The following is a description of a gene set: Human Gene Set: MURARO_PANCREAS_ALPHA_CELL from publication Muraro MJ, Dharmadhikari G, Grün D, Groen N, Dielen T, Jansen E, van Gurp L, Engelse MA, Carlotti F, de Koning EJ, van Oudenaarden A (PMID 27693023) studied in species Homo sapiens, and this is the list of marker genes: OGT, MUC13, DZIP3 (DAZ interacting zinc finger protein 3), APOH (apolipoprotein H), AK2, C12orf75, SLC38A10, ENSG00000274253, P4HTM, GDI1, NENF, ABLIM1, PRKCE, CDC42EP3, TCEAL3, ARRDC4, CHGB (NCBI Gene Id 1114), PVR, ISL1, ZBED5-AS1, SMOC1, GPR137B, KCNMA1, TENT5C, SERTAD4BP, CD46, STMN1, ALDH1A1, PCDHB4, PTGER3, AP1S2, SH3RF1, CHKA, DACH1, ENAM, DNAJA4, COX17, NME4, CTNND2, PDZK1, SPCS1, PLPPR4, SEM1, PARM1, CALM1, BEX1, UBB, FAR2P2, SSTR1, PTP4A3, H1-10, NPDC1, CFC1, RGS4, KCNK16, IVNS1ABP, IRF6, SNED1, NDUFA1, SCG5, UNC13A, FAM167A, NAA20, RSAD2, MANEAL (mannosidase endo-alpha like), HIGD1A, TRAK1, PTPRN, GK5, SGSM1, ESYT1, INA, ST8SIA1, CADPS, HERC5, MAGED2, TBL1X, FAP, PDE4D, KCNA5, KCNJ6, MBOAT2, CMIP, SLC7A14, SYP, EGFEM1P, ITM2B, TXNDC11, SSBP2, THEM6, COPE, G6PC3, MTMR7, IDS, PAK3, SLC37A4, ANAPC11, CKB, PDK4, SLC30A8, NDUFAF8, FAM210B, CPNE3, FYB2, LDLRAP1 (NCBI Gene Id 81862), ARL3, GSTA4, LOXL4, KCNMB2 (potassium calcium-activated channel subfamily M regulatory beta subunit 2), DPP4, SMIM24, PKM, TCTN1, CALCOCO2, TMEM17, TMEM176A, MYEF2 (myelin expression factor 2), HS6ST3, GCG, SCN3B, ABHD16A, PAX6, PITRM1, HLA-A, PSEN2, GFOD2, RIN2, GGA2, ANKH, F10, RNASE4 (ribonuclease A family member 4), CKMT1A, FGF12, PTPRD, CAMK2B, AP3B2, NPNT, NLGN2, REC8, PIGT, MMRN1, TMEM59 (NCBI Gene Id 9528), KCNQ1OT1, LRP11, HECTD4 (NCBI Gene Id 283450), CNIH2, COX7A2, CSRNP3, PGAP1, NOMO1, NSG2, BUD23, GC, PRPS1 (NCBI Gene Id 8254), ENPP2, CUTA, MPC2, CNNM1, FXYD3, BEX3, MLLT11, GPX3 (glutathione peroxidase 3), PLIN3, TMEM260, SCAMP1, HSD17B14, MRC1, GNG2, TM4SF4, CNKSR3 (CNKSR family member 3), NAV1, PAM, NOVA1, PLCE1, RGS9, RAB27A, TTR, PPP3CB, LUC7L3, ATP5MG, GNAS, NUCB2, GUSBP14, SERPINE2, ANXA6 (annexin A6), LSAMP, PRAF2, COX8A, BIVM, REEP4, GNG4, NFASC, MBD4, FXYD6, DEPP1, RGS17, NEUROD1, MOB1B, NOL4, SLC8A2, SH3GL2, PLK2 (NCBI Gene Id 10769), DAPK2, VAMP2, QPCT, ITPR1, IL6R, HMGB3, OAZ1, TMEM60, SLC22A17, UBL5, NRXN1, SGPL1, MAFB, ADCY1, IFI27L2, TMED3, CACNA1A, CSGALNACT1, CD99L2, ELAPOR1, OCRL, CD36, ZNF618, SMDT1 (single-pass membrane protein with aspartate rich tail 1), SIK3, GRM4, ASPH, ZKSCAN1, PFN2, PRKAR1A, GPAA1, SPC25, POPDC3, NAXE, ADA2, PKD2, C21orf58, GLS, ACVR1C, PLPP5, CRTAC1, SPTSSB, GPC6, HNF1A-AS1, ARX, NDUFB8, CEACAM19, PTPRN2, EPB41L3, MAMLD1, PTGER4, BEX2, SGSM2, ST8SIA3, BTG2, HIPK2, AIG1, KIAA0319, ZNRF1, ANXA7, TMEM178B, SDC2, VKORC1, RCAN2, SEC14L1, IFI6, PDXDC2P, C2CD4B, CHST9, CKMT1B (NCBI Gene Id 1159), CNTN4 (NCBI Gene Id 53943), CITED2, TOX3, TMEM9, TMEM258, CPNE8, USP25, PPP1R3B, UQCRQ (ubiquinol-cytochrome c reductase complex III subunit VII), ST18, PCSK2, PTS, ACLY, PYROXD2, DNER, PCDH17, SLC9A7, TENT5A, TCEAL5, SEZ6L2, MAGI2-AS3, NEURL1, COA3, TTC8, ADCY2, SESN3, SDK1, TUBA1B, STX16 (NCBI Gene Id 8675), FAM110B (NCBI Gene Id 90362), SLC29A1, CLU, VDR, A1CF, NDUFA7, ENPP1, UPB1, CPLX2, SERPINI1, SYT4, ROMO1, RAP1GAP2, EPHX2, FNDC3A, OSBPL6, KIF12, LGI2, VCF2, QDPR, TMEM176B, RIMBP2, HMGN3, NDUFC1, SDF2L1, VWA5B2, ZBTB41, SPINT2, YIPF6, MYL6 (myosin light chain 6), BCAR3, EDIL3, TMEM147, GDA, RADX, KCNK17 (potassium two pore domain channel subfamily K member 17), JADE1, TMX4, STXBP6, LINC00261, MAB21L3, CST3, CD200, FADS1, NUCB1, TCEAL2 (transcription elongation factor A like 2), CAPZB, GNE, PPP1R1A, APOL4, STX11, FBXW7, CNTN1, H2BC21, RUNDC3A, CRELD1, DNPH1 (2'-deoxynucleoside 5'-phosphate N-hydrolase 1), RHBDD2, BEX5, RAB29, USH1C, KLHL41, SLC38A4, PLP2 (proteolipid protein 2), NBDY, TUNAR, CCDC86, PTPRT, RAB26, PRKAG2-AS1, VSTM2L (NCBI Gene Id 128434), TSPAN2, CD82, IDI1, CPE, SLC35G2, FBXL16, KCNJ3, PDE3B, AGT, TBC1D9 (TBC1 domain family member 9), RAB3C, RAB3GAP2, MYH10, TMEM205, RTN1, GRAMD4, WDR59, PAPSS2, GADD45G, PNMA2 (PNMA family member 2), MAP7D3, BCKDHB, CEP126, SMARCA1, CERK, TMEM14A, SNHG6, IRX2, NPTXR, RFX6, LDB2, SPOCK3, MALAT1, ATP5MF, NT5C3A, ATP6AP2, IFIH1, RAB3B, LRATD1, CAMK2G, BACE1, LRRTM2, CD164, GNAI1, NR4A2, COPZ1, GRK3, MIA2, SSTR2, CD63, SERF2, ATRAID, VPS41, RTL5, TMEM80, CRYBA2, ATP2B1, FAM47E, CHGA, RPS6KA3, ATP6AP1, DNAJC12, RASSF5, MAGI2, BOLA3, RAB11A, TBC1D30, VPS26B, PEMT, PROX1, GCNT1, YIPF2, KCTD12, EMB, HMGN2, KDELR1, QSOX2, C1orf122, TMEM236, UQCR11, NIPSNAP3A (nipsnap homolog 3A), ADGRG2, CBX6, VGF, PGR, NDUFB11, LBH, FABP5, GCH1, H1-2, LCLAT1, TLCD4, IRX1, ITPK1, GRIA3, SMAP2, NRCAM, WFS1, PHTF2, SMARCA2, ALPK3, CNPY2, LIMCH1, SEZ6L, PAPPA2, PEG10, NDUFAF3, SESN2 (sestrin 2), SYT5, NAA38, SSX2IP, ARFGEF3, CRH, STC2, TPD52, FLNB, FEV, FSTL5, TSPAN7, MAN1A1, FKBP2, APLP1, SCGB2A1, SLC36A4, LRPAP1, TMEM164, CYSTM1, PDK3, CRMP1, KCNIP1, SYNGR4, PRLR, STMN2, ZDHHC14 (zinc finger DHHC-type palmitoyltransferase 14), CCDC18-AS1, COTL1, SLC7A8, P4HA2, C2CD4A, THRB, GNAZ, KLHL3, PCSK1N, TUBA1A, SELENBP1, ATXN2, ITFG1, CERCAM, SH3KBP1, SNU13, ARNT2, RIMS2, SRPK2, NPTN, SLC7A2, ABHD15 (NCBI Gene Id 116236), HSD17B12, TRNP1, HPS1, ARHGAP1, ECH1, GRSF1, G6PC2, PPP2R2B, SLC25A53, DPP6, CNIH3, APH1B, PCBD1 (pterin-4 alpha-carbinolamine dehydratase 1), ATP5F1EP2, MTSS2, TUSC3, CERS6 (ceramide synthase 6), SCG3, CACNA2D2 (calcium voltage-gated channel auxiliary subunit alpha2delta 2), ATP9A, ABI2, SLC29A4, MYO10, PCNX1, NDUFB2, SCG2 (secretogranin II), EMC10, PALLD, CSTF3, HMGN5, MAGED1, ELL2 (elongation factor for RNA polymerase II 2), COL9A2, SELENOI, DYNLRB1, TCTA, AHI1, PPM1K, SNAP25, KCNK3